The following is a description of a gene set: Primary active transport of a solute across a membrane, driven by exothermic flow of electrons from a reduced substrate to an oxidized substrate. Primary active transport is catalysis of the transport of a solute across a membrane, up the solute's concentration gradient, by binding the solute and undergoing a series of conformational changes. Transport works equally well in either direction and is driven by a primary energy source. studied in species Homo sapiens Human Gene Set: GOMF_OXIDOREDUCTION_DRIVEN_ACTIVE_TRANSMEMBRANE_TRANSPORTER_ACTIVITY, and this is the list of marker genes: COX5A, COX7B, COX6B1, COX5B, UQCRFS1P1, UQCRC1, MT-CYB, NDUFA3, MTCO2P12, MT-CO2 (NCBI Gene Id 4513), CYB561D2, NDUFA4, NDUFB8, MT-CO1 (mitochondrially encoded cytochrome c oxidase I), MT-ND4L, NDUFV3, MT-ND5, NDUFS1, MT-CO3, COX7A1, MT-ND3, UQCRH, NDUFS2, UQCR10, NDUFB7, NDUFA12, NDUFA7, NDUFS7, NDUFS5, NDUFB10, MT-ND1, COX7A2L, MT-ND2, NDUFA1, NDUFA5, NDUFS4, COX4I1, CYB561D1, NDUFV1, NDUFB4, NDUFB3, NDUFA6, NDUFV2, UQCRFS1, NDUFB9, NDUFS6, SURF1, NDUFA9, NDUFC2, NDUFB6, NDUFS8, NDUFB1, NDUFA8, NDUFC1 (NADH:ubiquinone oxidoreductase subunit C1), NDUFA10, CYC1 (cytochrome c1), CYB561A3, COX8A, CYBRD1, MT-ND6, NDUFS3, NNT, MT-ND4, NDUFA2, NDUFB2, NDUFB5